Given this list of marker genes TPPP, CNTN1, CD9, MIOS, MTMR2, PALS1, ABCA2, GPC1, ITGB4, FIG4, ERCC2 (NCBI Gene Id 7269), UGT8, TENM4, EPB41L3, CNTNAP1, MAG, ANK2, DICER1, GNPAT, PLLP, NCMAP, PMP22, here is a description of the gene set: The process in which the wraps of cell membrane that constitute myelin are laid down around an axon in the central or peripheral nervous system. species: Homo sapiens Human Gene Set: GOBP_MYELIN_ASSEMBLY